Given this list of marker genes ICAM1, METAP2, RARB, WNT4, NOTCH2, CD3D, WNT7A, OGDH, LAT, CD3E, SLC3A2, ALPL, CD247, FGF18, IL2RA, CX3CR1, NOTCH1, ENTPD2, here is a description of the gene set: Down-regulated in CD4+ T lymphocytes after 4 h treatment with 100 nM TSA. from publication Moreira JM, Scheipers P, Sørensen P (PMID 14606959) Human Gene Set: MOREIRA_RESPONSE_TO_TSA_DN species: Homo sapiens BACKGROUND: Histone deacetylase inhibitors (HDACIs) induce hyperacetylation of core histones modulating chromatin structure and affecting gene expression. These compounds are also able to induce growth arrest, cell differentiation, and apoptotic cell death of tumor cells in vitro as well as in vivo. Even though several genes modulated by HDAC inhibition have been identified, those genes clearly responsible for the biological effects of these drugs have remained elusive. We investigated the pharmacological effect of the HDACI and potential anti-cancer agent Trichostatin A (TSA) on primary T cells. METHODS: To ascertain the effect of TSA on resting and activated T cells we used a model system where an enriched cell population consisting of primary T-cells was stimulated in vitro with immobilized anti-CD3/anti-CD28 antibodies whilst exposed to pharmacological concentrations of Trichostatin A. RESULTS: We found that this drug causes a rapid decline in cytokine expression, accumulation of cells in the G1 phase of the cell cycle, and induces apoptotic cell death. The mitochondrial respiratory chain (MRC) plays a critical role in the apoptotic response to TSA, as dissipation of mitochondrial membrane potential and reactive oxygen species (ROS) scavengers block TSA-induced T-cell death. Treatment of T cells with TSA results in the altered expression of a subset of genes involved in T cell responses, as assessed by microarray gene expression profiling. We also observed up- as well as down-regulation of various costimulatory/adhesion molecules, such as CD28 and CD154, important for T-cell function. CONCLUSIONS: Taken together, our findings indicate that HDAC inhibitors have an immunomodulatory potential that may contribute to the potency and specificity of these antineoplastic compounds and might be useful in the treatment of autoimmune disorders.